The following is a description of a gene set: from publication Chen Y, Wang X (PMID 31504780) Genes predicted to be targets of miRBase v22 microRNA hsa-miR-5703 in miRDB v6.0 with MirTarget v4 prediction scores > 80 (high confidence targets). species: Homo sapiens Human Gene Set: MIR5703, and this is the list of marker genes: SYNPO2L, SCAMP1, MAN1A2, F9, ABHD16A, PLAGL2, CCBE1, AKAP13, FBXO28, FN1, SCN3B, ZNF133, SCGB2B2, RSPO4, ZBTB2, CHPF, FBXO46, FAAP20, THUMPD2, VPS29, FMNL3 (NCBI Gene Id 91010), PAFAH2, ASH1L, FNBP4, RHO, MS4A10, KLHL13, CD276, SNTB2, NT5C1B-RDH14 (NT5C1B-RDH14 readthrough), AQP1, TOX3, FCHSD2, R3HDM2, FBXW7, CYSLTR2, TCF12, SPATA33, KLHL42, AASDH, NHSL1, FBXO21, FAM135B, TRPM7, SPCS3, GPATCH2L, CDK6, ANKFY1, ASCC1, KMT2D, NTRK2, LRRC8B, AHCYL2, TMEM214, ZKSCAN8, MAF, PRR27, EBF1, ERBB4, KLHDC8A, PALM2AKAP2, EGR3, RECQL5, NECAP1, BNC2, PAK1, SAR1A, SLC26A10P, ZMAT3, SMG7, PLEKHG2, TMCC2, ARHGEF4, IDH1, CREB5, SASH1, CLTCL1, NFIC, ITGA9, BTK, CCDC9B, SEPTIN6, TAS2R14, NKAIN1 (sodium/potassium transporting ATPase interacting 1), SLC25A21, SLC7A6, ZNF22, RNF10, TNRC6B, LINC03040, KCND1, DICER1, CYB561A3, GIPC2, CDC20B, USP18, CEP85, SPG7, OPCML, VAMP1, DDX6, PREPL, CILP2, PRP4K, PPP3R1, LRP4, ELOVL5, SET (SET nuclear proto-oncogene), CDH7, ALDH16A1, GAS7, CPLX4, DUOXA1, BORCS7, FSTL4, PABIR2, SP1, ZC4H2, LPXN (NCBI Gene Id 9404), MSN, DNMT3B, SIAH3, FANCL, MTMR7, FAM131B, PDE1C, SRL, RASAL2, ABL2, BTN2A1, SSBP2, SLC46A1, ZFP3, EIF3J, RTL4, GNB4, PLAT, ING4, FBN1, CPM, GJB6, KIRREL1, ANKS1A, GALP, GPD1, PIK3CB, ADARB2, MECP2, PHF8, DOCK3, SVBP, TXNRD1, TMEM178B, LYPD6, FOXD2, FBXO32, CORO2B, SHF (NCBI Gene Id 90525), TTC22, ASB11, DSCAML1, MTCL2, FCGR1BP, EXOSC3, ZKSCAN2, ZDHHC7, CEP250, ST6GAL1, AAK1, ELF2, OTULIN (OTU deubiquitinase with linear linkage specificity), GYPE, TNFRSF21